The following is a description of a gene set: Tracheoesophageal fistula Human Gene Set: HP_TRACHEOESOPHAGEAL_FISTULA studied in species Homo sapiens An abnormal connection (fistula) between the esophagus and the trachea., and this is the list of marker genes: EIF4H, MID1, TERC, PDGFRB, TYMS, FANCC, CEP295, TBL2, METTL27, RTEL1, GTF2IRD1, BRIP1, WNT7A, PROKR2, NCF2, SOX3, PAICS (phosphoribosylaminoimidazole carboxylase and phosphoribosylaminoimidazolesuccinocarboxamide synthase), NOTCH3, RAD51C, HESX1, FANCG, BAZ1B, GREB1L, FANCL, XRCC2, RFC2, WNT9B, SLX4, FBN2, NCF1, DKC1, POLR1C, VPS37D, ERCC4, MYCN, FKBP6, GTF2IRD2, SEMA3E, FANCA, FANCD2, DNAJC30, GTF2I, RAD51, POLR1B, USB1, CYBA, UBA2, FANCB, ITGA8, RFWD3, GFRA1, SALL1 (NCBI Gene Id 6299), LIMK1, NPM1, RET, WRAP53, LMBRD1, ELN, BRCA1, SLC12A2, FANCM (FA complementation group M), NHP2, FANCI, NCF4, FOXF1, CYBB, BRCA2, UBE2T, CTC1, ARNT2, FANCE, ZIC3, POLR1D, POLA1, CHD7, TINF2, PALB2 (NCBI Gene Id 79728), BUD23, NOP10, OTX2, CYBC1, TMEM270, WBP11, FANCF, TCOF1, PARN, FGFR1, SCAF4 (NCBI Gene Id 57466), FGF20, HOXD13, STX1A, TERT, CLIP2 (NCBI Gene Id 84805), MAD2L2, SOX2